Given this list of marker genes PTH1R, DCSTAMP, RUNX1, BBLN, RASSF2, NPR2, CEACAM1, SIGLEC15, MDK, FAM114A1, RUFY4, ITGB3, IL18, EXT1, SPP1, AXL (AXL receptor tyrosine kinase), SEMA3C, CD38, TGFB2, CTHRC1, NPR3, LIPA, SYK, CST3, UBASH3B, YPEL4, BMPR2, CTSK, UMOD, ACVRL1, GREM1, EPHA2, IL21, TNFRSF11A, GPR55, MIR199A1, TCIRG1, FOXC1, EVA1A, TGFB1, ACE, SNX10, ADRB2, DEF8, CAPN1, GPR137B, FGF10, EFNA2, HAND2, IL2, RAB3D, ROCK1, PTK2B (protein tyrosine kinase 2 beta), ATG5 (NCBI Gene Id 9474), TMBIM1, SPP2, HRG, CBS, NOL3, PTH, LGR4, TMEM64, RAB7A, MIR143, MIR34A, MIR17, IL12B, FOXC2, NOX4, MIR214, P2RX7, FKRP, TPH1, NOTCH2, ENSG00000274276, DBH, P3H4, BAX, IL23A, HERC1, FLT4 (fms related receptor tyrosine kinase 4), MIR29B1, LEPR, TPP1, IL7, RAC2, C6orf89, SLC4A2, IL1A, SFRP1, NCDN, PTN, BGN, NPPC, IHH, LRRK1, MIR15B, PLG, CRB1, SUCO, CARTPT, ELF3, PML, CSPG4, HIF1A, CHD7, LRP5, MIR34C, SYT7, CDKN2A, FSHR, MDM2, VDR, CCR2, INPP5D, LIF, JAG1, F2R, IAPP, MC4R, NF1, IGF1, NOS3, BGLAP, MMP2, COL6A1, IGFBP5, GPR137, GNAT2, CYP1A1, BCR (NCBI Gene Id 729775), LTBP3, TIE1, AGER, PLEKHM1, THBS4, ARAP1, RBPJ, GJA5, MITF, FGF8, AGTR2, LEP, GJA1, PRKCA, DDR2, GPNMB (glycoprotein nmb), HOXA3, FOSL2, MIR199B, ADAM8, RSPO3, PPARG, TIMP1, PPP3CA, S1PR1 (sphingosine-1-phosphate receptor 1), CTNNB1, TMEM119, MIR20A, CSF1R (colony stimulating factor 1 receptor), NFKB1, NDP, BAK1, ACVR2B, FSHB, MEF2C, PDK4, BSX, IL15, MIR195, MIR27B, ACP5, TRAF6, SRC, CELA1, EDNRA, MIR34B, MMP14, CLDN18, CSK, ZNF675, ROCK2, TP53, WNT16, ATP7A, EPAS1, TNFAIP3, DOCK5, CAV1, AGT, IL6, HTR1B, DLL4, MIR16-1, GDF5, IL20RA, TNFSF11, CALCA, here is a description of the gene set: studied in species Homo sapiens Human Gene Set: GOBP_TISSUE_REMODELING The reorganization or renovation of existing tissues. This process can either change the characteristics of a tissue such as in blood vessel remodeling, or result in the dynamic equilibrium of a tissue such as in bone remodeling.